The following is a description of a gene set: Mouse Gene Set: GOBP_REGULATION_OF_SKELETAL_MUSCLE_FIBER_DEVELOPMENT studied in species Mus musculus Any process that modulates the frequency, rate or extent of skeletal muscle fiber development. Muscle fibers are formed by the maturation of myotubes. They can be classed as slow, intermediate/fast or fast., and this is the list of marker genes: Myog, Shox2, Bcl2, Myf6, Hdac9, Myod1, Lmod3, Hdac5, Fbxo22, Hdac4, Myf5, Actn3